The following is a description of a gene set: studied in species Mus musculus Mouse Gene Set: GOBP_POSITIVE_REGULATION_OF_OVARIAN_FOLLICLE_DEVELOPMENT Any process that activates or increases the frequency, rate or extent of ovarian follicle development., and this is the list of marker genes: Rac1, Mfn2, Src, Ptger4, Zp3 (zona pellucida glycoprotein 3)